The following is a description of a gene set: Human Gene Set: HP_HYDROPS_FETALIS The abnormal accumulation of fluid in two or more fetal compartments, including ascites, pleural effusion, pericardial effusion, and skin edema. species: Homo sapiens Hydrops fetalis, and this is the list of marker genes: GLB1, HADHA, PLD1, SLC17A5, RPL26, KLF1, GATC (glutamyl-tRNA amidotransferase subunit C), GATB, CALCRL, DYNC2I2, FAS, RYR1, QRSL1, NR1H4, DYNC2I1, SPTB, FLT4, WDR35, UROS, RPL11, PPP3CA, COL11A1, ADAMTS3, MCM10, GBE1, SLC26A2, EPB41, RPS24, FOXC2, GYPC, FLNB, KIF20A, THSD1, COL1A2, NEK1, WNT7A, SPTA1, ALG1, UROD, NSF, GATA1 (NCBI Gene Id 2623), CASP10 (caspase 10), AGGF1, RPL18, SCN4A, ADA2, PIEZO1, CHRNG, LZTR1, FOXF1, ENPP1, ALG9, AHCY, COL2A1, RRAGC, RPS28, KIAA0586, RPS17 (NCBI Gene Id 6218), RPL35, ALPK3, HBA1, PTH1R, RPS20, TSR2, VAC14, TRIP11, NEU1, LYN, GRIP1, RASA1, ESAM, GBA1, MECOM, RPS19, MMACHC, RPS26, CCBE1, RPL31, CRLS1, GUSB, RPL9, HSPG2, HBA2, CDAN1 (codanin 1), CTSA, LARS2, LBR, HEATR3, DYNC2H1 (dynein cytoplasmic 2 heavy chain 1), GAA, FASLG, SLC35D1, ALG8, RPS10, RHD, FAT4, IFT80, MGAT2 (alpha-1,6-mannosyl-glycoprotein 2-beta-N-acetylglucosaminyltransferase), RPL8, ABCC6 (ATP binding cassette subfamily C member 6), MUSK (muscle associated receptor tyrosine kinase), ASAH1, COL1A1, RPS29, RPL35A, NEK9, TALDO1, BSND, SOX18 (SRY-box transcription factor 18), RPS27, RPL27, EPHB4, MDFIC, CARS2, PIK3CA, PMM2, RPL5, TRIM37, RPS7, NDUFB10, PIGA, TAPT1, FIG4, SCN5A, PKLR, RPL15, RPS15A